Given this list of marker genes Map3k13, Dvl3, Grip1, Dvl1, Fzd4, Dvl2, Dlg4, Wnt5a, here is a description of the gene set: species: Mus musculus Mouse Gene Set: GOBP_POSITIVE_REGULATION_OF_NEURON_PROJECTION_ARBORIZATION Any process that activates or increases the frequency, rate or extent of the process in which the anatomical structures of a neuron projection are generated and organized into branches.